The following is a description of a gene set: Human Gene Set: GNF2_SPTA1 species: Homo sapiens Neighborhood of SPTA1 Neighborhood of SPTA1 spectrin, alpha, erythrocytic 1 (elliptocytosis 2) in the GNF2 expression compendium, and this is the list of marker genes: RPIA, TFDP2, BSG, SLC30A1, BLVRB, TRIM58 (tripartite motif containing 58), ISCA1, ERMAP, EIF1AY, BNIP3L, KAT2B, EPB42, KLF1, SLC22A4, HMBS, MARCHF8, TRAK2, NFE2 (nuclear factor, erythroid 2), ABCB6, FOXO3 (forkhead box O3), GYPA, ANK1, GCLC, ALAD, SELENBP1, KEL, CLIC2, H4C3, TFDP1, ALAS2, HBQ1, TMCC2, RHCE, MAP2K3, GATA1, TSPAN5, TSPO2, SLC12A3, ACSL6, GYPC, TRIM10, RAD23A, AHSP, MPP1, RHD, SLC6A8, FBXO7, HBD, CA1, OSBP2 (oxysterol binding protein 2, NCBI Gene Id 23762), XK (NCBI Gene Id 7504), SPTA1 (spectrin alpha, erythrocytic 1), GLRX5, SLC4A1, PPOX, RANBP10, SPTB, TAL1, EIF2AK1, H1-0, UROD, RNF123, ACKR1, GYPB, CDC27, SNCA, FECH, SMOX, GYPE, DCAF11, UBE2O, CA2, CROCCP2 (NCBI Gene Id 84809), MXI1, FBXO9, XPO7 (exportin 7), MINPP1, NUDT4 (nudix hydrolase 4, NCBI Gene Id 57236), RHAG, MARK3, CTSE